The following is a description of a gene set: species: Homo sapiens Vertebral arch anomaly A morphological abnormality of the vertebral arch, i.e., of the posterior part of a vertebra. Human Gene Set: HP_VERTEBRAL_ARCH_ANOMALY, and this is the list of marker genes: DDRGK1, SMAD4, CHST3, SLC35D1, NPR2, ANKRD11, GNPTAB, RMRP, RNU4ATAC, HNRNPR, PDE4D, LTBP3, EXOC6B, TONSL, JAG1, PRKAR1A, FGFR3, KIF22 (kinesin family member 22)